Given this list of marker genes DHX37, PROP1, CDH23, C14orf39, ROBO1, SLC30A7, NF2, FGD1, PIK3CA, PDGFB, SHOC1, HSD17B4, SUFU, KASH5, MCM9, BMP15, CYB5A, PNPLA6, XRCC2, PSMC3IP, ERCC6, AKT1, ANOS1, DNHD1, SOHLH1, NHLH2, MEIOB, SOX9, FANCM, TEX14, DIAPH2, GCNA, TEX15, CLPP, ZFPM2, PPP2R3C, LGR4, CT55, POU1F1, SNRPN (NCBI Gene Id 6638), FMR1, TERB2, KLHL10 (kelch like family member 10), FAM111A, GNRH1, TERT, NR0B1, CBX2, RNF212, FSHR, FOXL2, MCM8, FBXO43, PNLDC1, ESR1, SRY, TAF4B, TP63, NSMCE2, ZSWIM7, WWOX, NR5A1, SYCP2L, PDHA2, VAMP7, LHB, LHX4, FIGLA, DMXL2, SEMA3A, TRAF7, HESX1, WT1, CCDC34, CPE, CYP17A1, HROB, PRDM13, GDF9, MAGEL2, BAP1, ZMYND15, SMARCE1, FEZF1, OTX2, LARS2, NDN, TERB1, SPAG17, BMPR1B, SPATA22, CYP11A1, KISS1R, MOV10L1, NUP107, KISS1, CNBP, DNAH10, MSH4, SMARCB1, OCA2, SPIDR, SMO, POLA1, CFTR, MSH5, BNC1 (basonuclin zinc finger protein 1), SYCP3, POLR3H, TDRD9, MAP3K1, GATA4, LHCGR, POR, HFM1, ESR2, TAC3, ARMC12, LHX3, FKBP6, FSHB, RPL10L, NANOS1, AR, DHH, STAG3, TEX11 (testis expressed 11), MANF, MRPS22, SYCE1, CATIP, here is a description of the gene set: Human Gene Set: HP_ABNORMAL_CIRCULATING_GONADOTROPIN_CONCENTRATION species: Homo sapiens An anomaly of the circulating level of a gonadotropin, that is, of a protein hormone secreted by gonadotrope cells of the anterior pituitary of vertebrates. The primary gonadotropins are luteinizing hormone (LH) and follicle-stimulating hormone (FSH). Abnormal circulating gonadotropin concentration